Given this list of marker genes ADAM17, AKAP6, LPAR3, MTOR, NEDD4L, TRIM32, MIR199A1, PRKN, NCBP1, SYT14P1, GOLGA4, RIMS1 (regulating synaptic membrane exocytosis 1), PLAA, SDCBP, PRR5, L1CAM, DDX49 (DEAD-box helicase 49), EIF4G2, CFL1, KDM2B, CIB1, PAFAH1B1, SLC23A2, MAPKAP1, RICTOR, EDN1, H3-5, EXOSC2, ITSN2, CYBA, INS, DDX3X, SFN, YAP1, KLHL22, ZFYVE27, SFRP2, CDH4, EXOSC4, S100A9, BDNF, MEGF8 (multiple EGF like domains 8), PARP2, LIMK1, TRPV2, BCL11A, HYAL1, SLC44A4, IL9, SMURF1, SEMA5A, SYT4, UNC13A, H3-3A, EFNA5, SUPV3L1, S100A8, F2, AVPR1A, RNF157, RPTOR (NCBI Gene Id 654218), CDKL5, CDKN2AIP, CRYAA, SPHK1, FN1, AKT1, CPNE5, IGFBP1, ANAPC2 (NCBI Gene Id 29882), NGF, IST1, ISLR2, TWF2, H3-3B, TNFRSF12A (NCBI Gene Id 51330), KRT17, ZNF639, TAF9B, INO80, HBEGF, MAP3K13, CD38, MMP14, SMAD7, CPNE6, ACSL4 (NCBI Gene Id 4426), CXCL16, SLC25A33, TRPC5, SEMA4D, PRSS2 (serine protease 2), SYT3, MLST8, ARMC12, PSMD10, SYT1, CSNK2A1, SYT17, PAK1, MIR19A, TGFBR1, IL2, SLC9A1 (NCBI Gene Id 6548), CPNE9, CXCL12, MAP2K5, GDI1, IGF1, EGFR, VEGFA, MTPN (myotrophin), BRAT1, MIR208A, RND2, SRF, RASAL1, RIMS2, SEMA7A, PABIR1, EXTL3, CRK, RPS6KA1 (NCBI Gene Id 6195), MIR19B1, HDGFL2, POU4F2, AVP (NCBI Gene Id 551), EXOSC9, CDC42, DSCAM, BCL2 (NCBI Gene Id 596), PUM2, WNT3, N6AMT1, NRP1, UCN, HPN, LGI1, ADAM10, ERBB2, CSNK2A3, MACF1, RUFY3, NRG1, TEAD1, MFSD2A, DNPH1, EIF4G1, WNT3A, SHTN1 (NCBI Gene Id 57698), CEP43, SFRP1, DISC1 (NCBI Gene Id 80138), MUL1, CACNG7, MAPT, DERL2, NTN1, RPS6KA3, NTRK3, ADNP, ADCY10, SYT2, TGFB2, CRABP2, BMPR2, MAP1B, here is a description of the gene set: Human Gene Set: GOBP_POSITIVE_REGULATION_OF_CELL_GROWTH Any process that activates or increases the frequency, rate, extent or direction of cell growth. species: Homo sapiens